The following is a description of a gene set: studied in species Homo sapiens from publication Chen Y, Wang X (PMID 31504780) Human Gene Set: MIR3664_5P Genes predicted to be targets of miRBase v22 microRNA hsa-miR-3664-5p in miRDB v6.0 with MirTarget v4 prediction scores > 80 (high confidence targets)., and this is the list of marker genes: CAMTA2, RHAG, MEI4, ZNF572, ANKRD49, CDC27, ATP1B3, HLF, HPS5, PRTG, SLC22A3, PGS1, CCDC152, USP12, ITK, PPFIA1, TMEM185A, SLC35B4, CALCR, DNAJA2, ACVR2B, COL6A1 (NCBI Gene Id 1291), DNAJC16, DPP10, SAMD12, RAB3GAP2, MTDH, CEP120, PIK3R1, RASGRF1, ZNF532, ZMYM5, CAMTA1, BCOR, WWTR1, CYP39A1, ZNF655, CFHR5, KLHL36 (kelch like family member 36), SCAI, ARK2N, VPS13A, LIX1, RIPOR1, CNOT6L, TJP3, SLC4A4, NCOA3, PRR23E, PTPN11, GABARAPL2, KCND2, ADGRL2, KIF13A, DYNC2H1 (dynein cytoplasmic 2 heavy chain 1), PTPRJ, SLC30A4, CCSER1, SLC30A1, CD1E, SLC45A3, BMPER, CRISPLD1, CC2D1B, LRRTM3, CA2, HSD17B6 (NCBI Gene Id 8630), CYP27C1, C2orf49, ORC4, EFCAB5, SGCB, ITGB6, SETBP1